The following is a description of a gene set: Any process that activates, maintains or increases the rate of ubiquitin transferase activity. Human Gene Set: GOBP_POSITIVE_REGULATION_OF_UBIQUITIN_PROTEIN_TRANSFERASE_ACTIVITY species: Homo sapiens, and this is the list of marker genes: PLK1, MAGEC2 (MAGE family member C2), CDC14B, MAGEA2B, RPS2, CDC20, FZR1, ARRDC4, SKP1, BMI1, UBE2C, ARRDC3, BTRC, MAGEA2, UBE2S